Given this list of marker genes NT5C2, THUMPD2, SMARCC1, AKT1S1, CREG1, MDFIC, SFTPB, PXT1, NEPRO, ZDHHC22, ATL2, GNAO1, GDI2, ATP1B2, VPS36, GPR26, MECP2, BANF1, SLC39A10, RETREG3, ATP8A2, DLG2, CAPN5, MR1, C5orf46, TNIP1, SMAGP, ACAD11, APOBEC3B (NCBI Gene Id 9582), SENP1, ST3GAL1, RAB7B, LAMP1, SAPCD1, SLC2A5, HBP1, RARG, CREBL2, PITPNM3, CAPSL (NCBI Gene Id 133690), GLIS2, ERCC1, NSG2, PSMD11, MMP24, SLAMF7, TGM7, SLC8A3, HOXA3, SDC3, CDK5, CLEC2A (NCBI Gene Id 387836), ST8SIA3, SIGLEC5, TRPM3, here is a description of the gene set: Human Gene Set: MIR505_5P from publication Chen Y, Wang X (PMID 31504780) Genes predicted to be targets of miRBase v22 microRNA hsa-miR-505-5p in miRDB v6.0 with MirTarget v4 prediction scores > 80 (high confidence targets). species: Homo sapiens